Given this list of marker genes CYP17A1, HSD3B2, CYP11B1, POR, STAR, here is a description of the gene set: species: Homo sapiens Congenital adrenal hyperplasia A type of adrenal hyperplasia with congenital onset. Human Gene Set: HP_CONGENITAL_ADRENAL_HYPERPLASIA